The following is a description of a gene set: Genes having at least one occurrence of the motif CASGYG in the regions spanning 4 kb centered on their transcription starting sites. This matches the transcription factor binding site V$USF2_Q6 (v7.4 TRANSFAC). studied in species Homo sapiens Human Gene Set: USF2_Q6, and this is the list of marker genes: SMC3, SIRT1, UVRAG, VPS26A, SLCO1C1, RGL1, CA14 (NCBI Gene Id 23632), RAB30, TDRD1, GTF2H1, PSEN2, BRDT, VWA2, CACUL1, KRTCAP2, HHEX, AK2, POLR3C, FXYD2, HPS5, SCYL1, GAPDH, AMPD2, CNNM1, STX6, CHRM1, LDHA, IL15RA, CNST, SFXN2, ESRRA, LZTS2, RHEBL1, NRIP3, GUCY1A2, ERCC6, MFSD5, TFB2M, FXYD6, ATAD3B, RAB3IL1, EMC1, HLX, MYCL, MICAL2, RORC, SEC23IP, ADSS2, HOXC12, CPT1A, DIP2B, CBX5, EBNA1BP2, ATAD3A, ZMYND12, HOXC13, YBX3, MICU1, TIMM10, IVNS1ABP, FEN1, RBBP4, LMX1A, STMN1, PPCS (phosphopantothenoylcysteine synthetase), TAGLN2, RFX5, KMT2A, TEX12, SLC1A7, SERBP1, FCHSD2, TADA1, HPCAL4, PLBD1, ADAM12, RASGRP2, HMGN2 (high mobility group nucleosomal binding domain 2), NID1, CEP57, CELF1, POU3F1, H3-3A, EPB41, METTL13, LTBR, IPO7, REEP3, PRRC2C, IPO13, BATF2, PABPC4, FOXJ3, TRIM3, FGF6, RUSC1, CHD4, AK3, CTBP2, CIART, RPL22, COMMD3, SLC43A1, CGN, MAEL, COPZ1, RRP8, ARPC5, ARHGAP20, SCAMP3, ZZZ3, LHX9, NR0B2, ZNF593, CDC14A, CDKN2C, POGK, EPC1, LRP8, ZBTB40 (NCBI Gene Id 9923), RARG (NCBI Gene Id 5916), FAM76B, NRAS, RCOR2, NMNAT2, WDR77, ZBTB8OS, RLF, ATP5PB, TRIM46, ADGRB2, CUL5, SLC16A1, SLC38A2, UBE4B, HOXC11, ZFP91, KAT5, ATF1, DEPDC7, AGMAT, AP3M1, RPUSD4, REXO2, PITX3, TXNDC12, TGFB2, NKX2-3, ARL2, CSDE1, B4GALT2, NET1, ZNHIT6, E2F8, FABP3, TAF6L (NCBI Gene Id 55310), ATF7IP, FADS3, MACROD1, ATXN7L2, FGF19, ILK, NUDC (NCBI Gene Id 10726), TMEM86A, CFAP57, WEE1, TIAL1, AVPI1, FOXD3, EIF3A, B3GALT6, UBXN10, UBXN1, BCL9L, USP2, FOSL1, PTPRF, YBX1, HNRNPH3, SLC25A33 (NCBI Gene Id 84275), SORL1, HOXC5, RUSC1-AS1, B3GALT2, RAD9A, UBIAD1, PA2G4, PFKFB3 (NCBI Gene Id 5209), HPCA, MARCHF8, BCL9, ALDH3B1, DPAGT1, HNRNPF, TSSK3, POLR2L, BATF3, DCHS1, OGDHL, ERLIN1, LIN28A, RNF115, RTN4RL2, C1orf43, ARHGAP12, HNRNPA1, PFDN2, COPS7A, CCDC6, UBR4, RRP15, C2CD2L, CCAR1, BHLHE41, ZNF503, COL2A1, TSPAN4, IGSF22, PPRC1, ZMYM6, APOA5, SC5D, POLR3A, ATP6V0B, PLA2G4A, ADK, BLOC1S1, TMEM258, FKBP11, PLEKHA6, PAX6, LRFN4, BDNF, ALDH18A1, ACAP3, RRAGC, EIF4B, MTCH2, TSKU, MRTO4, TESK2, PPP1R3C, CTSF (cathepsin F), NIT1, SYT6 (synaptotagmin 6), CFL1, FAF1, DNTTIP2, PICALM, ARL3, GPD1, NAT10, ALX4, OPRD1